The following is a description of a gene set: Genes predicted to be targets of miRBase v22 microRNA hsa-miR-23c in miRDB v6.0 with MirTarget v4 prediction scores > 80 (high confidence targets). from publication Chen Y, Wang X (PMID 31504780) species: Homo sapiens Human Gene Set: MIR23C, and this is the list of marker genes: BBX, SDHD, AGAP1, NCOA6, CNR1, TNFAIP6, KMT5A, POU2F1, MARCKS, ATP11C, PPP4R4, KDM6A, NKAIN2, TEX30, BNIP3L, FRMD5, HYCC2, ROBO2, CHSY3, DENND4A, KLF3, ZNF257, RBM25, GAP43, SWT1, CNOT4, CAB39, MYCT1, AKAP12, MEF2A, SLC4A4, UHMK1, JMJD1C, MAB21L2, CRISPLD1, NEFL, SLC12A2, PRR14L, TMEM131L, CCDC186, APAF1, ZNF189, RBBP6, DOCK3, FBXO32, RETREG3, NTS, ZMYM2, NUS1, TRIM14, NUAK2, SERINC1, SEC14L1, IFIT5, CAMK2G, BNIP2, TRPM7, CELF2, PIK3R3, VCAN, MIGA1 (NCBI Gene Id 374986), BLCAP, MAP4K4, NLK, STON2, AUH, RAD51AP1, TMOD2, SATB2, CACUL1, FYB1, PRPH2, SENP6, BRWD1, PALS1, CLDN12, GSK3B, ERBIN, FOSB, STARD3NL (STARD3 N-terminal like), SOWAHC, NAP1L5, GET1-SH3BGR, ZFHX4, SLC38A1, BTBD8, NPY5R, HS6ST2, HDX, ZNF737, NFIA, ZNF652, UBN2, NLGN4X, FGD4, ARL8B, PDE4B, ACSL6, ORMDL1, ERBB4, PDIA6, CRLF3, KLHL7, NRXN1, SLC7A1, RAI14, ZDBF2, POU4F2, SEC23A, CCNG1, SLC1A1, LRAT, FZD5, ANXA10, WNK3, VEPH1, STX12, LYPLA1, MAP7, PARD6B, KPNA4, FRAT2, GLCE, ZNF287, CBFA2T2, FMR1, TNKS2, POM121C, RBPMS2, BLTP1, CCM2, NOL4, CCDC158, HSPA12A, C6orf62, LPGAT1, XIAP, PTPN4, TBC1D12, RBM47, KDM4A, NGLY1, NKX2-1 (NK2 homeobox 1), CDH1, CREBZF, C15orf32, BICD2, ZIC1, NDFIP2, RTF1, LRIG1, POM121, NSD2, DTNA, PPIF, PLAU, COL4A1, RNF38, CDK17, RXFP1, FASTKD3, CA2 (carbonic anhydrase 2), AMBRA1, CASP7, TMPO, NAA16, PLEKHH2, PKNOX1, SESN3, ANKRD50, THAP12 (THAP domain containing 12), TUSC2, MDFIC, SLC38A2, UBE2D1, SFT2D1, INTS6, YOD1, GPRC5B, PTEN, CPEB2, EOMES, CSE1L, NACC2, RPRD2, PRDM1, IGSF8, TLK1, CNTLN, PPP1R12A, ZNF721, MRC1, NSRP1 (nuclear speckle splicing regulatory protein 1), IPMK, MED12L, ELAVL4, MINDY2, GTDC1, MAML2 (mastermind like transcriptional coactivator 2), SPSB4, ADGRG2, ASXL3, PNRC1, KLHL28, ATXN7, NLGN4Y (NCBI Gene Id 375846), PCDH19, GNRHR, INPP5A, CLEC1A, ASAH2B (NCBI Gene Id 653308), CCDC71L, ANO4, KCNK5, MYH2, SAFB, EPHB2, NAP1L3, CBLL1, ZNF208, NAA50, DENND1B, CTCF, NDUFA2, PPP4R3B, NIN, TRHDE, TJP1 (tight junction protein 1), PNRC2, SRPK1, TTC7B (NCBI Gene Id 145567), ZCCHC2, MIA2, SIX4, ATP6V1E1, NIPSNAP2, NR6A1, ROBO1, RGS8, MIS18A, AP1S2, PLXNC1, HTR2A, CAMSAP2, PKP4, TRIM63, PIP4K2B, SEC24A, ADCY1, ZNF267, TBC1D15, ANKHD1, STT3B, NUFIP2, ATG12, ZNF90, FZD3, HMGB2, LONRF3, PPP2R5E, GABRG1, LMBR1, ZNF117, CALCRL, AUTS2, MTF1, ODF2, JCAD, EBF3, ENC1, ZIC4, TSNAX, ZNF506, GNG2, CIPC, CBLN1, PPARGC1A, BEX5, ZNF395, MT2A, ZNF655, GJA1, ELF2, SSH2, ATXN7L3B, IL12B, ZNF793, JARID2, LPAR1, TMEM135, PLAAT5 (phospholipase A and acyltransferase 5), TXLNG, ELOVL3, MET, RCN1, ZNRF2, TNPO1, STRN, ARHGAP20, REPS2, MAPRE1, AKAP11, PRTG, WHAMM, HEXIM1, ZBTB43, ZNF195, MED4, ALDH1A2, PAK2, IPO5, TCF24, TOP1, USP53, MBOAT7, BORA, VTI1B, NEDD4L, HOXD10, ENTPD5, EPSTI1, PDPK1, TNRC6B, SIPA1L1, SEC23IP, B4GALT4, TOX, PLCXD3, QSER1, SMS, ARNT2, ASF1A, LYZ, CXCL12, MTSS1, TRIL, ZNF469 (zinc finger protein 469), WEE1, TYMSOS (TYMS opposite strand RNA), RAB8B, ZNF680, CNN2, WDR37 (WD repeat domain 37), SCN2A, TMEM170A, CNKSR2, HDAC7, MCM4, WBP2, LHFPL2, WBP4, CBLB, PRKCE, HOXA1, ZNF99, CASP10, ZNF107, HS3ST3A1, EXOC3L4, GXYLT1, STK4, LIN54, TBR1, DDX47, UBE2R2, ADGRL2, NUAK1, TMEM33, AKR1C2, PRDM10, TTC23, TOX3, RAD21, TET3, MAP3K1 (NCBI Gene Id 4214), ZNF839, MAK16, IL6R, BTAF1, FAS, C2orf69, FUT9, VGLL3, ZNF30, PTGER4, ATXN1, RCOR1, GRM5, TAB3, CCNT2, PAK6, ABHD18, ADAM12, ADAM23, FBN2, ABRAXAS2, TMEM68, SERINC5, GLP2R, ESRP1, PPM1K, CGGBP1, B4GAT1, MICU3, SYT4 (synaptotagmin 4), INTU, LGR4, GLS, CUL3, TNRC6C, ZBTB44, SOX6, PDE7A, NRK, RALYL, TCP11L1, LIPH, NDUFA5, RAP2B (NCBI Gene Id 5912), COL4A5, MITF, CSNK1G3, SESN2, MTHFS, RFX3, LPP, ZNF138, DPP10, CDC40, UQCRFS1, ZNF765, TENT5A, VCPKMT, FGF2, NCOA2, UBE2K, ZNF420, ZNF468 (zinc finger protein 468), CHUK, TGFBR2, ISCA2, CLCN3, WNK1, AGPAT4, TGIF1, TMEM245, COL11A2, TTC39B, RAB11FIP2, RRAS2, RNF150, SOCS6, OSBPL8, PNMA2, GIMAP7, NEK6, ZNF292, ZIC5, DNAJC6, RUFY2, ADNP, GAS2L3, GPR22, CEP350 (centrosomal protein 350), ST20-MTHFS, AHCTF1, NUP50, SH3BGR, PKDCC, SCG5, IGSF10, FUT4, CAPRIN1, IPPK, MAP3K20, GUCY1A2, FREM1, ZBTB34, TMOD1, MCFD2, GGNBP2, SNRPG, G3BP2, ADAMTS6, ZC3H12C, HOXB5, ECHDC1, ZNF559, SLC16A6, ZNF730, ZEB1 (zinc finger E-box binding homeobox 1), REEP1, SYNJ1 (synaptojanin 1), NRXN3, PGRMC2, ZNF461, TRIB1, PKIA, MARCKSL1, SEMA4B, MEX3C, CALCR, UBE2O, TNFAIP3, RAP1A, SEH1L, ZBTB18, ZNF676, SSBP2, CHST7, GRK5, MAP4, MYH1, MBTD1, RORA, DIPK2A, PCMT1, FBXO25, CCL7, TMED5, CEMIP2, RAB39B (NCBI Gene Id 7489), COG3, TMEM38B, EGR3, TOP2B, SPHKAP, ATP11B, DHX15, CEP63, VKORC1L1, SNX5, FAM234B, ZNF716, RPL31, MTCL1, ZNF626, SV2B, STRN4 (NCBI Gene Id 29888), ELF4, DCBLD2, STAT5B, BACH2, DCUN1D1, CCNH, CBFA2T3, ZBTB2 (zinc finger and BTB domain containing 2), SMIM9, ETNK1, ZNF493, SPOCK1, TMEM263, N4BP1, PITPNC1, PTPRB (NCBI Gene Id 5787), RPP30, HNF4G, SPOPL (speckle type BTB/POZ protein like), SATB1, SHROOM2, PRELID2, EPAS1, CARD8, LAMP1, FOXP2, KDM5A, SEMA6D, NEK7, SLC4A7, MAP3K5, MAGOHB, CNOT6L, PRRG1, PAX9, CAMTA1, ESRRG, ANKRD33B, TXNRD1, RNF168, PCDH18, CCSAP, ANKMY2, NCOA1 (NCBI Gene Id 8648), TNRC6A, CPSF4, DOK6, C12orf76, CDS2, C3orf52, ELOVL2, MEIS1, HAS2, ATRN, SLC6A14